Given this list of marker genes NDC1, NUP62, NUP153, NUP210, SEC13, NUP50 (nucleoporin 50), NUP205, NUP188, NUP88, NUP85, NUP37, NUP54, NUP93 (NCBI Gene Id 9688), NUP42, NUP98, SEH1L, NUP155, NUP43, TPR, RAE1, NUP35, NUP214, NUP58, AAAS, NUP133 (NCBI Gene Id 55746), NUP160, NUP107, POM121, POM121C, RANBP2, here is a description of the gene set: Reactome Pathway: IPs transport between nucleus and cytosol studied in species Homo sapiens Inositol phosphates (IPs) synthesised in the nucleus are imported into the cytosol from the nucleus. The molecular details of these transport processes remain uncertain. part of: Inositol phosphate metabolism